The following is a description of a gene set: Abnormal dense granules species: Homo sapiens Human Gene Set: HP_ABNORMAL_DENSE_GRANULES Defective structure, size or content of dense granules, platelet organelles that contain granules proaggregatory factors such as adenosine diphosphate (ADP), adenosine triphosphate (ATP), ionized calcium, histamine and serotonin., and this is the list of marker genes: HPS5, HPS3, BLOC1S5, HPS6, AP3B1, LYST, HPS4 (NCBI Gene Id 89781), RUNX1, IKZF5